The following is a description of a gene set: species: Homo sapiens Human Gene Set: GOBP_FOREBRAIN_CELL_MIGRATION The orderly movement of a cell from one site to another at least one of which is located in the forebrain., and this is the list of marker genes: SLIT1, PEX13, LAMB1, FBXO45, AXL, POU3F2, SLIT3, BMERB1, FUT10, ROBO1 (roundabout guidance receptor 1), RAC1, SUN1, FEZF2, TYRO3, MBOAT7, COL3A1, DRD1, NR2E1, RTN4, DISC1, SRGAP2C, CDK5R2, SLIT2, FOXB1, CXCL12, CCDC141, RHOA, FOXG1, HTR6, OGDH, WDR47, SUN2, TNR, ZMIZ1, SRGAP2, PSEN1, SYNE2 (NCBI Gene Id 26075), LRRK2, SOCS7, RELN, EFHC1, ARX, CNTN2, MDGA1, EGFR, NRG3, GLI3, SRF, DRD2, ARL13B, DAB2IP, P2RY12, CTNNB1, CDK5, DAB1, NDEL1 (nudE neurodevelopment protein 1 like 1), LRP8, ADGRG1, POU3F3, LHX6, CDK5R1, EMX2, PEX5, DIXDC1, FGF13, PAFAH1B1, NKX2-1